The following is a description of a gene set: studied in species Homo sapiens Metaphyseal spurs Bony outgrowths that extend laterally from the margin of the metaphysis. Human Gene Set: HP_METAPHYSEAL_SPURS, and this is the list of marker genes: MATN3, TRPV6, DLK1, RTL1, DYNC2H1, TRAPPC2, MEG3, ATP7A, PCYT1A